Given this list of marker genes ARPC2, VAMP2, PAIP1 (NCBI Gene Id 10605), RPL11, MYOZ2, LTA4H, CD163, PNLIP, RABGGTA, DAD1, PFKFB1, SDHB, DNPH1, RPL34, ATP9B, AQP5, NIT1, SLC7A5, PRKCD, ALDH1B1, CLASP1, GPS2, MYO9B, HDAC5, CHAF1A, MYO1F, VASH1, TSC22D3, CDKN1A, MPHOSPH8, CBX7, BBC3, CYBA, MPG, ARB2A, PPBPP2 (NCBI Gene Id 10895), DOCK2, GSK3B, TSPAN31, AP2S1, SIPA1, LY86, MEF2C, PSMD4, TESK1, CYP4B1, ATOX1, VAMP5, IDH1, CYFIP1, FBXO7, ORC4, ATG9A, GLOD4, PATZ1, GBF1, MED22, HCLS1, ANXA5, RAE1, ATP5F1D, RXRA, SNRPD2, PHF20, GAS6, ADA, DNAJC13, BCL2L2, P2RX4, VAT1, NFYC, TF, CD33, BAHD1 (NCBI Gene Id 22893), PSMD9, LY6E, FAM3A, ACADS, PTK2B, ACAT2, CRK, RASSF2, TNFRSF14, POLR2E, BRWD1, RBBP6, DTNB, ZNF80, CCDC57, TXNIP, ASF1A, PAK2, KPNA6, ACOX1, ACVR1, SRRM2 (serine/arginine repetitive matrix 2), CAPN1, DHCR24, LRRC37A2, VOPP1, IK (IK cytokine), POLR3C, ST3GAL6, ZNHIT1, AHNAK, RPS13, ATP6V0E1, CCND3, RPL21, RIN2, TMEM268, MAP2K3, OAS1, ATP5PB, STAMBP, ALDH3A2, COX6B1, SLC46A3, PDIA4, PLAG1, NELFE, TBCE (NCBI Gene Id 6905), NBR1, MCC, PTPA, SMARCC1, ENTPD6, NR1H3, DAP, RPS27A, POM121, PTGIR, NEK2, LDLRAD4, POU6F2, ACADVL, TMEM184B, COL6A2, LILRA1, PDCD11, PTAFR, ABO, ATP2B2, ZNF268, F13A1, ARF3, VSIG4, NUP98, OSGEP, CAMK1, LBX1, GPAA1, DNAH7, FCN1, BTF3, RNF113A, UFD1, IFFO1, CD72, KCNB2, RAC2, PLOD3, COPA, NDUFS8 (NCBI Gene Id 4728), NDUFS2, TPD52L2, CASP8, ACO1, TAF5, POLR2J, SELENOP, SLC37A4, SREBF2, FKBP1A, SDHC, PPIH, DGCR2, KCNAB2, ZP2, IL10RA, TRIAP1, MAP4K2, SH3BP1, FOXO3, ATP4A (NCBI Gene Id 495), MISP, NDRG2, ADGRG6, NAP1L4, CTSK, PSKH1, HTR7, PDXK, FLOT2, MTMR1, HNRNPUL1, TLK2, TRIM14, CYB5R1, TMEM131L, here is a description of the gene set: studied in species Homo sapiens Human Gene Set: GSE360_CTRL_VS_T_GONDII_MAC_UP Monocyte-derived dendritic cells (DC) and macrophages (MΦ) generated in vitro from the same individual blood donors were exposed to five different pathogens, and gene expression profiles were assessed by microarray analysis. Responses to Mycobacterium tuberculosis and to phylogenetically distinct protozoan (Leishmania major, L. donovani, Toxoplasma gondii) and helminth (Brugia malayi) parasites were examined, each of which produces chronic infections in humans yet vary considerably in the nature of the immune responses they trigger. Genes up-regulated in comparison of macrophages versus macrophages exposed to T. gondii. from publication Chaussabel D, Semnani RT, McDowell MA, Sacks D, Sher A, Nutman TB (PMID 12663451)